The following is a description of a gene set: Catalysis of the hydrolysis of a phosphoric monoester, releasing a phosphate. Human Gene Set: GOMF_PHOSPHATASE_ACTIVITY species: Homo sapiens, and this is the list of marker genes: ENPP1, PPP1R2P1, TIPRL, PPP1R2, INPP5E, CIP2A (cellular inhibitor of PP2A), PTPRB, PTP4A3, DUSP13A, PLEK, CABIN1, PTPRQ, PTPRC, PIKFYVE, SYNJ2 (synaptojanin 2), NT5M, UBLCP1, PANK4, DUSP2, PTPRD, LPIN2 (lipin 2), PFKFB4, ATP1A1, DUSP5, PPEF2, PTPRJ, URI1, PPP1R14C, MTMR14, DUSP4, PLPPR1, PHACTR1, PLPPR3, ACP6, BCKDK, PPM1J, PPP1R27, EPM2A, PPP3CA, PLPP1, PTPN13, PPP3CC, PTPRF, CDC14A, PLPP3, PPP1R8 (NCBI Gene Id 5511), DUSP12, FBP1, SBF1, PPP4R3A, CA3, CTDSP2, DNAJC6, INPP5A, TNS3, PTK2, PPP1R9B, INPP5B, CTNND1, PTPN7, DUSP22, PIP4P1, PPP4R3C, PPM1B, PNKP, PTN (pleiotrophin), AMBRA1, CALM1, ACP1, PLPP6, PDP2, STYXL2, PTPN22, PHOSPHO1, DUSP29, FRA10AC1, ACP4, DUSP8, STYXL1 (NCBI Gene Id 51657), YWHAB, PPP1CB, PPP6R2, TNS2, EPHX2, PHPT1, SSU72L3, PTEN, RCAN1, PLPP2, GNA12, HDHD2, PHLPP2, PPM1M, PHLPP1, EYA4, DUSP6, MINPP1, CTDNEP1, DUSP11, APTX, ENOPH1, PTPRH, PLPPR5, ALPG, PPM1G (protein phosphatase, Mg2+/Mn2+ dependent 1G), ATP1A2, PPM1H, CD33, B3GAT3, HDDC2, HACD2, PLPPR4, PPP4R1, PIP4P2 (phosphatidylinositol-4,5-bisphosphate 4-phosphatase 2), PDP1, PPP2R2A, PPP1R37, GTF2F1, ALPI, SYNJ1, PTPRK, PPP6R1, PTPA, NT5DC3, PHACTR4, SSU72L4, PPP1R3E, PPP3R2, NT5DC2, PPP1R10, PTPMT1, NT5DC4, PABIR1, SSH2, DUSP9, PPP2R1B, MDP1, PTPRO, MTMR6, PPM1N, PFKFB3, PPP2R1A, LPIN3, PTPRM, THNSL2, PDXP, PPP1R26, PTPN11, SSU72L2, NT5C, NT5C1A, EYA3, SLC39A10, PHOSPHO2, PPP1R16A, EYA2, CDC14B, CALM3, PPM1K, PHACTR3, CILP, PPP1R14D, DUSP26, PPA2, ZEB2, PPM1D, PTPRS, ACP2, LMTK2, CILP2, DUSP16, PTPRT, PPTC7, PTPN18, CNEP1R1, INPPL1, ENSA, PTPRG, CDKN3, IMPA2, DUSP19, PPP2R2C, SH3RF2, MTMR10, IMPA1, RCAN2, LCK, MTMR12, OCRL, CDC25B (cell division cycle 25B), PLPP7, PTPRN, PUDP, LGALS3, DUSP21, DUSP3 (dual specificity phosphatase 3), EYA1, PPP1R1A, NT5C3A, NANP, PTPRZ1, G6PC1, IGFBP2, LHPP, RCAN3, PPP1R16B, PPP4R2, PGP, PPME1, MTMR7, PPP2R3B, DUSP13B, PPP4R3B, PTPN12, SGPP1, PPP1R3D, MTMR1, IGBP1, SSH3, PTPN9, YWHAE, PTPN14, BOD1, ANKLE2, ITGA1, PPP2R2D, ILKAP, SSU72L6, INPP5K, PPP1R1B, PTPN5 (NCBI Gene Id 84867), DMPK, PRUNE1, MYH3, PPM1A, PSPH, PPP2R5C, INPP5J, VRK3, FIG4, PXYLP1, MYOZ1, TAB1 (TGF-beta activated kinase 1 (MAP3K7) binding protein 1), NT5C1B, DUSP23, ELFN1, CTDSP1, TNS1, BMP2K, PTPN2, PPP2CA, PPP1R17, PPP2CB, NT5E, PPP1CA, SIRPA, SSU72L1, PLPP5, CALM2, ALPP, PPP1R36, PPM1F, PPP6C, PPP2R3A, G6PC3, FBP2, SGPP2, INPP4A, IGFBP3 (NCBI Gene Id 3486), MYH6, MTMR11, PP2D1, ALPL, PPP1R3B, SACM1L, SAG, PPP1R15B, TESC, MTM1, DUSP7, NT5DC1, ACP7, PPEF1, VCAN, PPP1R7, INPP1, DUSP15, CPPED1, PTPRU, PGAM5, ARMT1, PPP1R1C, CTDP1, PTPRA (protein tyrosine phosphatase receptor type A), PPP1CC, PPP2R2B (protein phosphatase 2 regulatory subunit Bbeta), PLPPR2, PPP3R1, PPM1E, PTP4A1, PTPDC1, TIGAR, PPP1R2B, HSP90B1, MTMR2, PPP2R5B, ACP5, CDCA2, PPP5C, PTP4A2, ACP3, DUSP1, PTPN4, PTPN1, PPP1R12B, PPP2R5A, PLPP4, PPP1R3C, DUSP28, MTMR8, INPP5F, CDC25C, G6PC2, CTDSPL, PFKFB2, SBF2, CRY2, SSU72, FRS2, ELFN2, PTPN21, CDC14C (NCBI Gene Id 168448), SET, LPIN1, PALD1, PPP3CB, SSH1, PPP4C, MYH8, PPP1R15A, PPP1R35, PFKFB1, PTPN6, PPP1R12A, DUSP14, RPAP2, PTPN20, INPP4B, PPP1R14B, PPP4R4, HTT, PTPN23, BPNT1, ARPP19, PTPRN2, DUSP10, BMP2, PPP6R3, MTMR4, PTPN3, PTPRR, SSU72L5, RNGTT (RNA guanylyltransferase and 5'-phosphatase), CTDSPL2, STYX, TIMM50, EIF2AK2, PPP2R5D, PPP1R2C (PPP1R2C family member C), HSP90AB1, MTMR3, PPP2R5E (NCBI Gene Id 63385), PABIR2, SHOC2, MGAT5, PPP1R12C, PTPRE, DLG1, TPTE, INPP5D, PABIR3, NT5C2, ANP32E, PPM1L, TPRN, UBASH3B (NCBI Gene Id 84959), PPP1R14A, CDC25A, PHACTR2, CAMK2G, NT5C3B, NOCT (nocturnin), DUSP18, BPNT2, PPP1R11, TPTE2